The following is a description of a gene set: part of: Oncogenic MAPK signaling NF1 is a RAS GAP that stimulates the intrinsic RAS GTPase activity, thereby shifting the RAS pathway towards the inactive state. Loss-of-function mutations in NF1 have been identified both in germline diseases like neurofibromatosis 1 and in a range of sporadically occurring cancers. These mutations, which range from complete gene deletions to missense or frameshift mutations, generally decrease NF1 protein levels and abrogate RAS GAP activity in the cells, resulting in constitutive RAS pathway activation. studied in species Homo sapiens Reactome Pathway: RAS signaling downstream of NF1 loss-of-function variants, and this is the list of marker genes: SPRED3, KRAS, SPRED2, HRAS, SPRED1, NF1, NRAS